Given this list of marker genes PSMA2, SEM1, DVL2, DVL3, PSMA7, PSMC3, PSMB4, PSMC4 (proteasome 26S subunit, ATPase 4), PSMC5, PSMD14, UBB, KLHL12, PSMA1, PSMD8, RPS27A (NCBI Gene Id 6233), PSMB5, PSMD7, ADRM1, PSMC1, CUL3, PSMD12, PSMD1, PSMB1, PSMA3, PSMD6, UBC, PSMB3, PSMC2, PSMA6 (NCBI Gene Id 87553), DVL1, PSMA4, UBA52, PSMD13, PSMD2, PSMD11, PSMB6, HECW1, PSMC6, PSMB2, RBX1, PSMA5, PSMB7, DACT1, PSMD3, here is a description of the gene set: Reactome Pathway: Degradation of DVL species: Homo sapiens DVL protein levels are regulated by both proteasomal and lysosomal degradation. The E3 ligases HECF1, ITCH and KLHL12:CUL3 have all been shown to contribute to the polyubiquitination and subsequent degradation of DVL. DVL stability is also regulated by its interaction with DACT1, which promotes degradation of DVL in the lysosome. part of: TCF dependent signaling in response to WNT